Given this list of marker genes Ppargc1b, Tmem225, Mef2c, Plek, Gpld1, Uri1, Ifng, Hpn, Ccdc159, Tmem132c, Bmp2, Npnt, Chp2, Ppp1r42, Mtmr9, Tnf, Chp1, Ppp1r17, Epm2a, Bag4, Rock1, Ripk3 (receptor-interacting serine-threonine kinase 3), Cdk5rap3, here is a description of the gene set: Mouse Gene Set: GOBP_REGULATION_OF_PHOSPHATASE_ACTIVITY Any process that modulates the rate or frequency of phosphatase activity. Phosphatases catalyze the hydrolysis of phosphoric monoesters, releasing phosphate. species: Mus musculus